Given this list of marker genes SMAD2, BMP2, NOTCH1, HEG1, CCM2, BMP7, SOS1, FLRT3, NKX2-6, TBX20, WT1, HAND2, RPGRIP1L, DLL4, BMP5, TBX5, SMAD3, WNT5A, here is a description of the gene set: species: Homo sapiens Human Gene Set: GOBP_PERICARDIUM_DEVELOPMENT The process whose specific outcome is the progression of the pericardium over time, from its formation to the mature structure. The pericardium is a double-walled sac that contains the heart and the roots of the aorta, vena cava and the pulmonary artery.